Given this list of marker genes RALGAPA1, NDE1, SEZ6L, FANCA, AK2, SLC25A24, IQGAP1, UTY, RGS17, PPP1R3B, APH1A, here is a description of the gene set: Genes predicted to be targets of miRBase v22 microRNA hsa-miR-151a-5p, hsa-miR-151b in miRDB v6.0 with MirTarget v4 prediction scores > 80 (high confidence targets). from publication Chen Y, Wang X (PMID 31504780) species: Homo sapiens Human Gene Set: MIR151A_5P_MIR151B